Given this list of marker genes WDFY1, TXK, TMA16, GABPA, KCTD5, GABRG3, TRIM11, HIF1A, CPB1, TNIP2, ZSCAN26, SPON2, IFRD1, HMGXB3, ETFRF1, NDEL1, CXXC1, GRM8, SYNJ2BP, GGA2, UBTF, TAB2, VAC14, ACBD3, NSUN4, CSF1R, CAP2, PREB, TMED7, MED1, ATG3 (autophagy related 3), TAF8, FASLG, CDK14, WWTR1, IMP4, RPP25L, PDCD5, STXBP3 (NCBI Gene Id 730947), NUP188, BBLN, PUF60, SLC25A22, RIMOC1, RIOK1, AGPAT5, FMR1NB, YAE1, SKIC2, SLC25A15, FAM50A, ZNF347, KLK4, THUMPD3, KLF13, ZNF329, ZFP36, NR4A1, MYOC, CLK4, EIF3A, RIOX2, KRT33B, TMOD2, RPP40, ZNF296, SRSF10, PSME2, IRF3, MMAA, MSL1, PTPRC, RPL9, GFOD2, OVCA2, SRSF9, KANSL1, COL7A1, TEX261, CEP41, ZRSR2 (NCBI Gene Id 8233), PPP2R3A, CCSER2, STRN4, HMX1, CCDC134, RAB6B, KRR1, R3HDM1, RARS1, CCDC107, TAF10, ELOVL1, COMMD4, DHX15, COPS8, RRP7A, MYC (MYC proto-oncogene, bHLH transcription factor), EXD2, MIA3, SF3A3, UPF1, YIPF5, LAT, MESD, MED14, PRDX6, SCAF8, RRP8, POLRMT, RBM25, PYCR1, UFM1 (NCBI Gene Id 51569), CDIP1, IFFO2, FBXO21, USP19, C19orf25, SH2B3, CLK2, GTPBP6, RBM12, EXOC6, POU6F1, MRPL55, PWP2 (PWP2 small subunit processome component), ADH1C, TNFSF8, CLTC, PIP4K2C, SNRNP70, RPF1, FUBP1, KLHL22, MS4A1, FMC1, SAC3D1, NAP1L4, NUDT6, CIAO3, PNPO, M6PR, NSUN2 (NOP2/Sun RNA methyltransferase 2), STK17B, ARPC2, PURB, MBD3, NAA30, MRPS12, UBAP2L, CD40, PDCD7, RPAP3, OTOG, CBFA2T2, FAM162A, ATXN2, NSUN5, EIF4A3, SELENOW, MAL, UBE3C, HSPBP1 (HSPA (Hsp70) binding protein 1), SPPL3, HOXB3, REXO1 (NCBI Gene Id 57455), LEMD2, NPY4R, COPB1, ANKIB1, CHD1L, CFP, NFE2L2, DPH7, FBXW11, LRPPRC, MGAT2, FAM114A2, SIMC1, CHD4, EFTUD2, ZNF623 (zinc finger protein 623), SYNE4, ELMO3, BTG4, LIPT2, PNKP, SH3GL1, TSPAN9, PIM3, NR4A3, AURKAIP1, SAMM50, SAFB, PAPOLG, IL17RA, GSN (gelsolin), OR51B2, UBE2J2, SDCBP2, here is a description of the gene set: Human Gene Set: GSE15330_WT_VS_IKAROS_KO_LYMPHOID_MULTIPOTENT_PROGENITOR_DN Regulation of lineage potential and transcriptional priming by Ikaros. New insight is provided into a bivalent regulation of lineage priming in the HSC and its lympho-myeloid restricted progeny the LMPP by the lymphoid lineage-determining factor Ikaros Whereas Ikaros is responsible for the activation of a cascade of lymphoid expression programs and for the establishment of lymphoid potential from the HSC to the LMPP it is also responsible for the repression of stem cell and erythroid genetic programs that are incompatible with further lineage restrictions emanating from the LMPP Genes down-regulated in lymphoid-primed multipotent progenitors: wildtype versus IKZF1 knockout. from publication Ng SY, Yoshida T, Zhang J, Georgopoulos K (PMID 19345118) studied in species Homo sapiens